Given this list of marker genes POMGNT1, TMEM98, COX7B, ARL3 (NCBI Gene Id 403), SMC3, RPS24, CCDC22, POMT2, PCARE (photoreceptor cilium actin regulator), PEX6, BEST1, RPL11, GMPPB, SNRNP200, ALDH1A3, ADAMTS10, TRIM44, RBBP8, CRYBB3, NELFA, RDH12, MAB21L1, RNASEH2B, RNU7-1, BUB1B, PEX16, METTL27, DHX38, FGFR2, GRHL2, NAA10, EYS, TBL2, BBS1, TRAIP, RPL9, SMC1A, GJA1, REEP6, PEX2, ZMIZ1 (NCBI Gene Id 57178), IDH3B, RP9, PCNT, CSGALNACT1, PRPF3, CPLX1, CYP1B1, RPL15, PYCR1, PEX10, COMT, HEATR3, BRD4, NDP, CRX (cone-rod homeobox), YAP1, TMEM270, SEC24C, ZEB1, SKIC2, RPS28, PRPS1, POMGNT2, PEX5, PRPF31, EIF4H, FREM2, TBX1, RPL26, AHR, B3GALNT2, NOD2, VPS37D, DHCR7 (NCBI Gene Id 6589), TREX1 (three prime repair exonuclease 1), IDH3A, MERTK, SEMA4A, RPS26, RPL35A, PEX26, USH2A, NIPBL (NCBI Gene Id 25836), ANKRD55, NR2E3, POMT1, MFRP, ARVCF, GLIS3, GTF2IRD1, LETM1, RREB1, GP1BB, RPL31, CEP152, RPE65, CREBBP, HGD, TTC8, PEX14, PRPF4, RAD21, ADAMTS3, GUCA1B, RPS10, PTPN2, GNAQ, RPL8, SLC7A14, SRY, MAK, HLA-DRB1, KIF11, DKC1, SH3PXD2B, SKIC3 (NCBI Gene Id 9652), RPL18, HIRA, RPS17, BCOR, PEX11B, PROM1, CDH11, ARL6, PIK3R1, RPGR, PDE6A, RFC2, FKTN, SOX2, OTX2, FKBP6, XYLT1, ELN, POMK, DNA2, RIGI, ZNF469, CLN3 (CLN3 lysosomal/endosomal transmembrane protein, battenin), RNASEH2A, COL11A1, RPL35, OFD1, YARS2, PTPN22, POLG2, GZF1, RS1 (NCBI Gene Id 6247), RPS29, NDRG1, COL8A2, PUS1, PDE6B, FAM50A, IL2RB, RPS15A, NSD2, PRPH2, NCF1 (neutrophil cytosolic factor 1), ZFX, FAT4, PITX2, GTF2I, NLRP3, MAF, ANKLE2, TUB, ARL2BP, GTF2IRD2, KDSR, RPL27, WDR36, CRYBA2, ATR, RPS20, DSE, PTCH1, DHDDS, CLRN1, EBP, PLK4, RP2, CNGA1, PTCH2, ZNF513, ADA2, ATRIP, PEX3, NCAPG2, LOXL1, CD247, DPYSL5, BUB3, ESCO2, EFEMP1, LTBP2, RRM2B (ribonucleotide reductase regulatory TP53 inducible subunit M2B), LRAT, PEX12, TWIST1, NFIX (nuclear factor I X), PRSS56, COL2A1, NDUFB11, RXYLT1, ABCA4, CNGB1, SIX6 (SIX homeobox 6), CISD2 (NCBI Gene Id 56831), NF1 (neurofibromin 1), SCAPER, CENPE, NRL, FAM161A (FAM161 centrosomal protein A), PRR12, GJB3, FGFR3, BTNL2, RHOA, FOXE3, FBN1, TEK, COL3A1, LARGE1, CCBE1 (NCBI Gene Id 147372), STUB1, TULP1, WASHC5, COL4A1, BBS2, PDE6G, IMPG1, FGF10, CANT1, NHS, HCCS, ARHGEF18, MASP1, FZD4, ACVR1, TBC1D20 (TBC1 domain family member 20), PIGG, BUD23, CCDC28B, BAZ1B, PRPF8, WFS1, SAMHD1, CC2D2A, B3GAT3, SLC25A4, RPS7, CHST14, CRB1, CTBP1, KIAA1549, CRYAA, RPS27, ADAMTSL1, FKRP, WT1, CBS, CHD6, CRPPA, BDNF, IFT140, KIZ, MYMK, AGK, STAT4, TRIP13, RHO, RAX, PEX19, TKFC, IDUA, CEP57, FOXC1, RP1, RPS19, COL18A1, HDAC8, FSCN2, OCRL, DCN, IFT172, CHRDL1, SPATA7, ADAR, FAS, RLBP1, GJB4, RECQL4, TAF6, MAFA, CFAP418, B3GALT6, LRP5, NUP85 (nucleoporin 85), CHST3, ZSWIM6, FLNA, GSN, IFT88 (intraflagellar transport 88), TOPORS, ADAMTS17, RPL5, HGSNAT (NCBI Gene Id 8119), VPS35L, PAX6, CERKL, RP1L1, DNAJC30, SUFU, BUB1, HRAS, PRPF6, STX1A, IFIH1, FUT8, VSX1, TRPM3, OPTN, CLIP2, PEX13, OVOL2, ASB10, AKT1, NEK2, DAG1, EXOSC2, AGBL5, RGR, ZNF408, SLC4A4, CA4, ARSB, PRDM5, MAG, ROM1, RBP3, JMJD1C, NTF4, LIMK1, IMPDH1, SBF2, SAG, KCNA4, MYOC, IL2RA (interleukin 2 receptor subunit alpha), IMPG2, LMBRD2, LSM11, TIMP3 (TIMP metallopeptidase inhibitor 3), ANTXR1, PLOD1, PRCD, PIK3C2A, GATA1, CDHR1, RNASEH2C, AHI1, RNU4ATAC, BMP4, LMX1B, PXDN, B3GLCT, UFD1, B4GAT1, VCAN, ATOH7, TSR2, EP300, TGFB1, PEX1, KLHL7 (NCBI Gene Id 55975), here is a description of the gene set: Human Gene Set: HP_GLAUCOMA species: Homo sapiens Glaucoma refers loss of retinal ganglion cells in a characteristic pattern of optic neuropathy usually associated with increased intraocular pressure. Glaucoma